The following is a description of a gene set: part of: Diseases associated with glycosylation precursor biosynthesis GALM is a cytosolic enzyme that catalyzes the interconversion of beta-D-galactose to alpha-D-galactose. GALM conversion of b-GAL to a-GAL is required prior to a-GAL phosphorylation by galactokinase (GALK), the first committed step of galactose catabolism.<br>Mutations in GALM are associated with galactosemia type 4 (MIM 618881). Affected individuals generally present with mild symptoms which may include abnormal galactose levels, transient cholestasis and cataracts; more severe cases are associated with damage to kidney, liver and brain. species: Homo sapiens Reactome Pathway: Defective GALM causes GALAC4, and this is the list of marker genes: GALM